Given this list of marker genes Gad1, Atp6v1c1, Syt11, Atp6v1f, Clint1, Atp6v0e2, Adam10, Tyrp1, Rassf9, Picalm, Rab27a, Ap1s3, Inpp5f, Slc17a8, Lyz1, Sgip1, Ap1s1, Folr1, Ap3b2, Rab8b, Ap2a1, Arc, Epn2 (NCBI Gene Id 78669), Htt, Slc2a4, Tnk2, Vps16, Atp7a, Dvl2, Atp6v1g2, Snap91, Ctla4, Steap2, Edn1, Ap1m1, Synrg, Sort1, Dnm1, Atp6v0b, Abcb4, Astn2, Snx18, Rab13, Vps41, Cpne2 (NCBI Gene Id 66677), Atp6v1a, Hip1r, Ap2b1, Aak1, Ngfr, Cemip, Gas7 (growth arrest specific 7), Dnajc5, Astn1, Snx3, Tbc1d5, Rab3a, Lrp1, Aftph, Dennd1b, Ston2, Epn1, Btbd8, Igf2r, Cltc, Atp6v1d, Hip1, Ap1s2, Bcap31, Dvl1, Rnasek, Tgoln1, Cracr2a, Heatr5b, Dennd1a, Scamp1, Ece1, Vti1a, Rab27b (NCBI Gene Id 80718), Lyz2, Ap2s1, Rab14, Atp6ap1, Dnajc6, Atp6v1h, Cltb, Hax1, Rgs19, Clvs2, Dnm2, Pheta2, Vwf, Gopc, Spg21, Tmed10 (transmembrane p24 trafficking protein 10), Wipi1, Dab2, Atp6v0a1, Epn3, Furin, Vamp3, Clrn1, Myo1e, Ap3b1, Scyl2, Enthd1, Ocrl, Necap1, Atp6v1e1, Necap2, Ap1b1, Vamp2, Fcho1, Eps15, Aqp2, Dennd1c, Atp6v0d1, Gak, Vps11, Otof, Clvs1, Numb, Mall, Rab35, Plcg1, Ap4b1, Myo6, Lmbrd1, Rab12, Clba1, Gpr107, Rab8a, Gad2, Slc5a7, Reep6, Atp6ap2, Atp6v1b2, Vps33b, Gga2, Adcy8, Nrgn, Dbnl, Ap2a2 (NCBI Gene Id 97365), Pheta1, Pik3c2a, Vps18 (VPS18 CORVET/HOPS core subunit), Cpne6, Syn1, Slc18a3 (NCBI Gene Id 20508), Rnf216, Ap1m2, Atp6v0c, Syp, Ap2m1, Unc13d, Pank1, Fcho2, Vps33a, Clta, Ap1g2, Snx9, Ap1g1, Ston1, Sh3bp4, here is a description of the gene set: A vesicle with a coat formed of clathrin connected to the membrane via one of the clathrin adaptor complexes. studied in species Mus musculus Mouse Gene Set: GOCC_CLATHRIN_COATED_VESICLE